The following is a description of a gene set: Any process that modulates the frequency, rate or extent of signaling pathways initiated by the cross-linking of an antigen receptor on a B- or T cell. Human Gene Set: GOBP_REGULATION_OF_ANTIGEN_RECEPTOR_MEDIATED_SIGNALING_PATHWAY species: Homo sapiens, and this is the list of marker genes: BTRC, ELF1, PLCL2, PTPN2, RELA, NFAM1, KCNN4, DGKZ, STAP1, GBP1, CD19, RPS3, FCMR, MIR18A, PHPT1, DUSP3, PTPN22, CEACAM1, BTNL2, GPS2, PRNP, LIPA, PRKD2, RC3H1, CD81, PRKCH, ITPRIPL1 (NCBI Gene Id 150771), LPXN, LGALS3, CSK, CMTM3, CBLB, PTPRC, CYLD, LYN, TRAT1, UBR2, THY1, PTPRJ, CD160, SH2D1A, UBASH3A, CCR7, CD72 (NCBI Gene Id 971), LILRB4, SLC39A10, BTN2A2, PTPN6, GCSAML (germinal center associated signaling and motility like), FCRL3, FCGR2B, PAWR, LAPTM5, RAB29, MALT1, GCSAM, TESPA1, DUSP22, CD22, FOXP1, BCL10, NCK1, LCK, MIR34A, EZR, IKBKG, ADA, PVRIG, MIR19A, CARD11, SLA2, CD300A, CD226, NECTIN2